The following is a description of a gene set: species: Homo sapiens Human Gene Set: GSE17721_POLYIC_VS_CPG_12H_BMDC_DN mouse primary BMDCs were stimulated with tlr ligands and gene expression changes were profiled on Affymetrix arrays Genes down-regulated in comparison of dendritic cells (DC) stimulated with poly(I:C) (TLR3 agonist) at 12 h versus DC cells stimulated with CpG DNA (TLR9 agonist) at 12 h. from publication Amit I, Garber M, Chevrier N, Leite AP, Donner Y, Eisenhaure T, Guttman M, Grenier JK, Li W, Zuk O, Schubert LA, Birditt B, Shay T, Goren A, Zhang X, Smith Z, Deering R, McDonald RC, Cabili M, Bernstein BE, Rinn JL, Meissner A, Root DE, Hacohen N, Regev A (PMID 19729616), and this is the list of marker genes: POLR3D, ADORA2B, DNAJB6, NIBAN2, AP4S1 (NCBI Gene Id 11154), ECE1, EIF5A (eukaryotic translation initiation factor 5A), SELENOS, FARSA, SRSF10, GNL3, SRM, GHDC, DUSP2, ARHGEF10L, ACSS2, HINT1, SSRP1, DDX10, ACO1, OTUD6B, BSG, LAMTOR1, HSPA4, SPRY1, MED8, DDX18, GTF2E2, GTF3A, ZNF48, GPATCH4, CCL24, FASN, GLMN, SRSF1, NFATC3, TRPM5, PSTPIP2, ANGPTL2, AOAH, CLEC4A, CDKN2B, CTU1 (NCBI Gene Id 90353), RAB10, MRPS28, ABCC1, B3GALNT2, ACAD9, JMJD6 (NCBI Gene Id 23210), CA13, MRPS7, MEFV, DDB1, SLC7A7, RRN3, SLC47A1, RAP1GDS1, IPO7, PMP22, EIF2S3, MPHOSPH8, CCL21, SLC52A2 (solute carrier family 52 member 2), ALPK2, TMA7, UFM1, PDLIM7, CDK4, MRPL41, FCGR2A, XYLT2, MRPL12, CHID1, COX6A1, SLC12A3, NCBP2 (nuclear cap binding protein subunit 2), REXO2, PBDC1, RAD51, LTV1 (LTV1 ribosome biogenesis factor), TESK1, NRSN1, LRRC59, APPBP2, ID1, RNASEK, TOMM6, TRAF3IP2, SALL1, ACVR1B, ELK3, TUBGCP5, HJURP, CCL13, SRSF6, NOC2L, MTF2, PRMT3, GDF15, STUB1, PRKCB, ACLY, AKR1B1, ZNF639, KRT2, PPIC, PLAT, LMO4, DARS1, LYRM2, PSMG1, ATXN7L3, COL5A1, KIFC3, ZNF276, RNF26, GSS, ELOC, UBE2W, UQCRFS1, ANP32B, FAM169A, FBXO15, SPRYD7, FN1, SLC31A1, SCN10A (sodium voltage-gated channel alpha subunit 10), HSD3B7, RNF11, DNAJC10 (NCBI Gene Id 54431), ADRA2A, MYO5A, MC2R, PABIR1, SYCN, DCAF13, IKBKB, LRRC58, FAM118A, MANF, DPP3, SLC25A10, DENND6A, PEX12, ATAD3A, EIF4G2, CYB5A, FTH1, ARHGAP24, RPA2, RNF128 (ring finger protein 128), SFXN3 (NCBI Gene Id 94083), BYSL, FDFT1, FGF21, EIF4E, RHOA, PDE8A, ECD, POLE3, FDPS, USP39, SLC40A1, DRG2, INSM1, NDUFB4, CTBP2, CLCC1, BOP1, MTAP, HCK, ASH2L, FAM133B, IVD, ITSN1, KCMF1, MFSD14A, ZC3H8, CDC25A, WIPI1, PUM3, STT3A, HADHB, MTDH, NCKAP1L, IFI44L, SMIM30 (NCBI Gene Id 402587), CRISP3, ARL1, TPP2, PDCD5, HNRNPDL, SLC7A2, PEA15, SLC6A8, GRK2, HOXA13, DENR, LAMA4, MCM3